The following is a description of a gene set: studied in species Homo sapiens Human Gene Set: GOBP_REGULATION_OF_ENDODEOXYRIBONUCLEASE_ACTIVITY Any process that modulates the frequency, rate or extent of endodeoxyribonuclease activity, the hydrolysis of ester linkages within deoxyribonucleic acid by creating internal breaks., and this is the list of marker genes: GZMA, SIRT1, HMGB1, PRKCD, NPM1, AKT1, RPS3